Given this list of marker genes CAT, ATP1A1, AS3MT, SDHA, GSTO1, SOD1, MT-ND1, UQCRFS1, SOD2, COA3, VDAC1, here is a description of the gene set: Arsenic metabolism and reactive oxygen species generation Human Gene Set: WP_ARSENIC_METABOLISM_AND_REACTIVE_OXYGEN_SPECIES_GENERATION species: Homo sapiens